The following is a description of a gene set: Reactome Pathway: Defective CYP2U1 causes SPG56 Cytochrome P450 2U1 (CYP2U1) catalyses the hydroxylation of arachidonic acid, docosahexaenoic acid and other long chain fatty acids, generating bioactive eicosanoid derivatives which may play an important physiological role in fatty acid signaling processes. Defects in CYP2U1 can cause Spastic paraplegia 56, autosomal recessive (SPG56; MIM:615030), a neurodegenerative disorder characterised by a slow, gradual, progressive weakness and spasticity of the lower limbs. species: Homo sapiens part of: Metabolic disorders of biological oxidation enzymes, and this is the list of marker genes: CYP2U1